Given this list of marker genes MEIS1, LRRN1, PPARGC1A, CCNL1, CADM2, RORB, PAK5, VAMP2, NUAK1, PARD6B, SF1, PCGF3, ATMIN, C11orf87, TCERG1, MLX, FOSB, SP3, CHD7, FOXP1, AFF1 (NCBI Gene Id 83116), SETD2, ZNF217, POU4F2, HOXA11, TLE4, ARID2, BACE1, EIF2S2 (eukaryotic translation initiation factor 2 subunit beta), NFIX, EIF4G2, CAMSAP2, LARP4B, MEX3C, HAPSTR1, RER1, TCF12, BMP2, PITX2, TFAP4, ZCCHC14, ADAM10, HSPA4, TMEM47, FAF2, ABCA8, CBX4, EP300, SLC35D3, RAB38, MAP2K4, NR4A3, MSX1, PDPK1, CILK1, GADD45A, RNF214, EIF3A (eukaryotic translation initiation factor 3 subunit A), EN1, EDAR, RNF38, BHLHE40, ABAT, MTREX, KIF20A, CYP26B1, NOVA1, ETV5, ZDHHC5, HLF, QKI, EPHA8, RC3H1, RSF1, PARP8, SP1, PLPPR4, AMD1, ACTN4, TMEM108, PKIA, IQSEC2, ACTN1, ATXN1, NPTX2, GOPC, LTBP1, HAPLN1, RBSN, VCPKMT, PAPPA, PDE7B, ARHGEF40, SRPK2, BANK1, PMPCB, FMR1, GBX2, BSDC1, LIN9, DCAF6, NCOA1, IL15RA, HERC2, OCRL, HOXA1, SEZ6, MBNL2, PHF21A, DUSP6, TLX3, WNT5B, MECP2, PRDM1, METRNL, MEX3B, PCDH10, MGAT4A (alpha-1,3-mannosyl-glycoprotein 4-beta-N-acetylglucosaminyltransferase A), NR3C1, NFKBIZ, NEO1, NKX2-2 (NK2 homeobox 2), AFF4, DUSP8 (NCBI Gene Id 1850), ADGRL2, CLIP4, NHLH2, NLGN1, RREB1, HOMER1, PPP2R2C (NCBI Gene Id 5522), ETV6, ZEB2, ATP1A1, HR, ARHGAP6, RALGDS, ZNF236, MAP2, SOX4, SLC38A3, ZCCHC24, ST8SIA2, DIPK2A (NCBI Gene Id 205428), CCNE2, NUMB, PELI1, ASCL1, RUNX2, WDR11, FAM135A, STMN2, OSBP, CEMIP, PNRC1, BRD10 (NCBI Gene Id 158358), SYNE1, RGS7BP, PHRF1, SLITRK1, NR4A2, ATP8B2, DACH1, BRINP3, SCN2B, CAPZA2, PKNOX1, NR2F2, CNTN4, CHST2, SRSF7, PRKCD (NCBI Gene Id 5580), STYX, ZDHHC9, TMEM161B, PDE4D, SYT1, LCA5, CAPRIN1, ARL15, VWC2, BOLA3, TNRC6A, ZNF711, ARL2BP, HOXA10, WNT5A, ARHGAP28, SP4, ZNF131, ZNF423, CEBPB, DZIP1L, TRAPPC8, IL10, HIVEP2, PDE4B, HES1, SCN5A, CD47, LDLRAD4, MKX, BMPER, HDHD2, PLAG1, NIPBL, HECTD1, MTMR12, MAP4K3, GNB2, DMD, FNIP1, YTHDF3, TMSB10, FGFR2, PPP6R1, NTF3, FOXG1, CAND1, CSMD2, PAQR3, LEMD3, GATA3, LARP1, RAB10, PROK2, SPRY2, PAXIP1, RFX4, CRIM1, STARD13, GPM6A, AFAP1L2, FBXO42, TXLNB, RELCH (RAB11 binding and LisH domain, coiled-coil and HEAT repeat containing), SMAD6, SERTAD2, EYA1, DENND4A (DENN domain containing 4A), ZER1, TGFA, MED13, ESRRG, MAPK6, ABR, ANLN, FKBP1A, MEF2D, ST8SIA4, UST, WDR20, MAP2K6, PURA, BICD2, PMEPA1, PIKFYVE, SMARCAD1, CRTC2, FNDC3B, RALA, SOCS4 (NCBI Gene Id 122809), RAI1, WNT16, ZC3H7B, MED12L, UBE2H (NCBI Gene Id 7328), CPEB4, BRD8, MBLAC2, MMP14 (NCBI Gene Id 4323), TEAD3, ARHGAP5, FRMPD4, NUMBL, SYBU (NCBI Gene Id 55638), MOB4, VEZF1, DR1 (down-regulator of transcription 1), UBE2E3, NMT1 (NCBI Gene Id 4836), LRP1B, NOG, NCOA6, FOXO1, here is a description of the gene set: Genes having at least one occurence of the motif TATTATA in their 3' untranslated region. The motif represents putative target (that is, seed match) of human mature miRNA hsa-miR-374 (v7.1 miRBase). species: Homo sapiens Human Gene Set: TATTATA_MIR374